The following is a description of a gene set: studied in species Mus musculus The chemical reactions and pathways resulting in the formation of hyaluronan, the naturally occurring anionic form of hyaluronic acid. Hyaluronan is a type of non-sulfated glycosaminoglycan composed of the repeating disaccharide unit beta(1,4)-D-glucuronic acid-beta(1,3)-N-acetyl-D-glucosamine. Mouse Gene Set: GOBP_HYALURONAN_BIOSYNTHETIC_PROCESS, and this is the list of marker genes: Nfkb1, Ap2a1, Hyal1 (hyaluronoglucosaminidase 1), Has2, Has3, Cltc, Tgfb1, Abcc5 (ATP-binding cassette, sub-family C member 5), Pdgfb, Smpd3, Ccnd3, Has1, Il1b, Egf, Ptger4